The following is a description of a gene set: Mouse Gene Set: chr10C3 species: Mus musculus, and this is the list of marker genes: Poc1b, Mir3966, Gm8613, Gm5427, C030005K15Rik, Dcn, Gm34297, Gm6859, 4930556N09Rik, Lum (NCBI Gene Id 17022), Atp2b1, Gm8601, Galnt4, 4930525C09Rik, Phxr2, Gm33981, Ccer1, 4930473O22Rik, Gm20091, Epyc, Gm18515, Gm10754, Gm25658, Kera, Btg1 (NCBI Gene Id 380657), 4930459C07Rik, Gm33843, Gm8633